Given this list of marker genes FBLN1, LDB2, SPARCL1, PAPPA, ALDH1A1, ASPN, DAB2, here is a description of the gene set: Cancer cells differentiate along specific lineages that largely determine their clinical and biologic behavior. Distinct cancer phenotypes from different cells and organs likely result from unique gene expression repertoires established in the embryo and maintained after malignant transformation. We used comprehensive gene expression analysis to examine this concept in the prostate, an organ with a tractable developmental program and a high propensity for cancer. We focused on gene expression in the murine prostate rudiment at three time points during the first 48 h of exposure to androgen, which initiates proliferation and invasion of prostate epithelial buds into surrounding urogenital sinus mesenchyme. Here, we show that androgen exposure regulates genes previously implicated in prostate carcinogenesis comprising pathways for the phosphatase and tensin homolog (PTEN), fibroblast growth factor (FGF)/mitogen-activated protein kinase (MAPK), and Wnt signaling along with cellular programs regulating such 'hallmarks' of cancer as angiogenesis, apoptosis, migration and proliferation. We found statistically significant evidence for novel androgen-induced gene regulation events that establish and/or maintain prostate cell fate. These include modulation of gene expression through microRNAs, expression of specific transcription factors, and regulation of their predicted targets. By querying public gene expression databases from other tissues, we found that rather than generally characterizing androgen exposure or epithelial budding, the early prostate development program more closely resembles the program for human prostate cancer. Most importantly, early androgen-regulated genes and functional themes associated with prostate development were highly enriched in contrasts between increasingly lethal forms of prostate cancer, confirming a 'reactivation' of embryonic pathways for proliferation and invasion in prostate cancer progression. Among the genes with the most significant links to the development and cancer, we highlight coordinate induction of the transcription factor Sox9 and suppression of the proapoptotic phospholipid-binding protein Annexin A1 that link early prostate development to early prostate carcinogenesis. These results credential early prostate development as a reliable and valid model system for the investigation of genes and pathways that drive prostate cancer. studied in species Mus musculus Early prostate development genes (up-regulated at 48 hr dihydrotestosterone) which are also up-regulated in high grade prostatic intraepithelial neoplasia (PIN) vs invasive cancer. from publication Schaeffer EM, Marchionni L, Huang Z, Simons B, Blackman A, Yu W, Parmigiani G, Berman DM (PMID 18794802) Human Gene Set: SCHAEFFER_PROSTATE_DEVELOPMENT_AND_CANCER_BOX6_UP